Given this list of marker genes INO80C, FBXO21, KISS1R, CCNO, FAXC, PXMP2, ANKRD18B, UBE2QL1, KCTD6, MANEAL, CDK19, BRI3BP, ZNF195, FZD1, CXXC5, MAP3K21, TAF4, RBM25, E2F7, PHF2 (NCBI Gene Id 79448), RPA1, SFMBT1, UGT8, ZNF483, ADCY3, FGF9 (NCBI Gene Id 2254), DTL, STXBP1, PTCH1, DYM, DDAH1, FAM171A1, BCOR, EPHX4, ANKH, FGFR3, SHISA8, INSR, SLC16A6, RECQL4, ATRNL1, TEAD4, CDKN2C, FRAT1, PSIP1, POLE2, AKR1B1, GNAS, ENO2, CDKN2A, GPR137B (NCBI Gene Id 7107), ADGRB2, GNAL, SHANK3, RPL17, GLRB (NCBI Gene Id 2743), JPH1, HACE1, SAMD1, CRELD2, SAC3D1 (NCBI Gene Id 29901), CCNE1, CHST2, AP1S2, GINS1, KANK2 (KN motif and ankyrin repeat domains 2), CAMKK2, SLC30A4, GCH1, MMP15, TMEM158, PCOLCE2, GPR27, PUM3, SRSF7, CENPX, KDM2B, MACIR, BCL2L11, PLCL2, RAVER2 (ribonucleoprotein, PTB binding 2), ENTPD1-AS1, EEF1A2, RASEF, SLC27A3, TFDP1, AK4, GSE1, EZH2, B4GALT6, ZNF367 (NCBI Gene Id 195828), PEG10, LRP4, C6orf136, ALDH5A1, MYB, CCNE2, NIN, CHML, TIAM1, NSG1, DIS3L, RAB15, NCR3LG1, LRP8, FEN1, SIN3B (SIN3 transcription regulator family member B), DGKQ, CRY1, MBOAT1, CIZ1, CIBAR1, MIRLET7BHG, SMAD6, CHD7, SOX12, PXYLP1, NASP, CEBPA, ZDHHC23, INHBB, PHTF2 (putative homeodomain transcription factor 2), DNAJC9, RRAGD, CMPK2, ATAD2, WNT5A, FUT11, MDN1 (NCBI Gene Id 23195), ANKRD18A, LYPD6, ZBTB42, TMEM106C (transmembrane protein 106C), TBC1D9, PTGS1, NR2F1, AKT1, ABCG2, HRK, ABCC10, NCKIPSD, SSX2IP, PWP1, NIPA1, SBK1, EPB41L4B, PRRG4, TMEM214, CCND3, SOBP, EPB41L4A, EIF4A1, TLCD1, FAM222A, TMOD2, ABCB10, TPPP, CDKN1C, CHST1, NEMF, NETO2, EML6, NUP155 (NCBI Gene Id 9631), MFHAS1, NAT9 (N-acetyltransferase 9), FANCA, REEP1, TSHZ1 (NCBI Gene Id 791257), TLCD3A, SRSF6, TMEM97 (NCBI Gene Id 27346), PLPP3, RTN4R, HELLS, KHDRBS3 (KH RNA binding domain containing, signal transduction associated 3), WHAMMP4, MIR449A, ARHGAP8 (NCBI Gene Id 23779), IL17RB, KDM4B, TAF1D, NFATC3, RIPPLY3, PCNA, ZNF703, GKAP1, SMIM43, SCN8A, PFKFB3, PLXND1, DPY19L1, NHERF1, WIPI2, KCTD15, PDE8A, CSPG5, CCP110, RUNX3, DVL3, TRIM3, ABHD15, EPHA2, USPL1, SH3BGR, SCNN1A, TSPAN5, POLE, NEFL, PKN3, TENT5A, SREBF1, PHF10, GAS5, HECA, SLC35G1, ZWINT, PIN1, TRIM7, METTL21A, DCLRE1B, HEY1, LIN7B, ZNF275, TNC, ARFGEF3, DONSON, SYNM, RETREG1, SIX5 (SIX homeobox 5), NOL4L, MRAS, FOXQ1, CEP78, TM6SF1, CAMK2N1, RDH13, IL1B, LRIG1, TNFAIP3, DCK, RAB26, FERMT1, SLC25A12, SHROOM1, TMEM200B, CHST7, CD83, here is a description of the gene set: Human Gene Set: BILD_E2F3_ONCOGENIC_SIGNATURE from publication Bild AH, Yao G, Chang JT, Wang Q, Potti A, Chasse D, Joshi MB, Harpole D, Lancaster JM, Berchuck A, Olson JA Jr, Marks JR, Dressman HK, West M, Nevins JR (PMID 16273092) studied in species Homo sapiens Genes selected in supervised analyses to discriminate cells expressing E2F3 from control cells expressing GFP. The development of an oncogenic state is a complex process involving the accumulation of multiple independent mutations that lead to deregulation of cell signalling pathways central to the control of cell growth and cell fate. The ability to define cancer subtypes, recurrence of disease and response to specific therapies using DNA microarray-based gene expression signatures has been demonstrated in multiple studies. Various studies have also demonstrated the potential for using gene expression profiles for the analysis of oncogenic pathways. Here we show that gene expression signatures can be identified that reflect the activation status of several oncogenic pathways. When evaluated in several large collections of human cancers, these gene expression signatures identify patterns of pathway deregulation in tumours and clinically relevant associations with disease outcomes. Combining signature-based predictions across several pathways identifies coordinated patterns of pathway deregulation that distinguish between specific cancers and tumour subtypes. Clustering tumours based on pathway signatures further defines prognosis in respective patient subsets, demonstrating that patterns of oncogenic pathway deregulation underlie the development of the oncogenic phenotype and reflect the biology and outcome of specific cancers. Predictions of pathway deregulation in cancer cell lines are also shown to predict the sensitivity to therapeutic agents that target components of the pathway. Linking pathway deregulation with sensitivity to therapeutics that target components of the pathway provides an opportunity to make use of these oncogenic pathway signatures to guide the use of targeted therapeutics.